The following is a description of a gene set: Genes predicted to be targets of miRBase v22 microRNA mmu_miR_1264_5p in miRDB v6.0 with MirTarget v4 prediction scores > 80 (high confidence targets). studied in species Mus musculus from publication Chen Y, Wang X (PMID 31504780) Mouse Gene Set: MIR_1264_5P, and this is the list of marker genes: Tmem17, Calu, Gbp4, Cyp2s1, Srebf1, Gbp6, Glra2, Exd2, Stom, Btbd3, Ankrd44, Wnt9b, Tspan7, Sh3gl2, Rcan2, Prkg1, Csde1, Paip1, Simc1, Gtf3c4, Ubfd1, Med13l, Rarb, Meis2, Capn7, Kctd6, Txlna, Zc3h14, Tmem128, Elp4, Grem2, Dcp1a, Eya1 (EYA transcriptional coactivator and phosphatase 1), Unk, Sp3, Loxl4, Crebzf, Mrap, Cbl, Fhip2a (NCBI Gene Id 226252), Gjb4 (gap junction protein, beta 4), Ppp1r3a, Cpne3, Gm8817, Acat2, Ehd2, Gch1 (GTP cyclohydrolase 1), Gbp10, Mef2c, Myo15a, Gbp8, Bmp6, Crtam, Dynlt3, AB124611, Fmnl2, Tmem132c